Given this list of marker genes TTC39C, PSMB8, KCTD5, CDS2, ROCK1, ALS2, PLEKHO2, CASP1, NFATC1, ESCO1, FOXC1, RBKS, AHR, KIAA0319L, FHDC1, MCUB, THBD, ARSI, TUSC2, SOX18, PASK, SLC38A2, N4BP3, SYNGR2, EIF2AK2, ADI1, DLX3, CEBPA, RAB20, CD300LD, MRPS6, PALLD, TRIP12, TBC1D14, NFIL3, CTDSP2, PTGER2, ZNF207, ANGPTL2, MAF, TMEM131, IL10, ITGAE, TMEM267, ANKRD33B, HOXB4 (homeobox B4), KHDC1L, PROP1, NUDT22, RNF41, PTMS, TMEM268, ABCG1, IER5L, SUSD2, LIMA1, NPY2R, EDEM2, ST8SIA4, CYFIP1, RNF135, MMD, ABCB1, CD83, RBM38, RNF19B, HAUS3, AXL, SLFN12L, POGLUT2, NRP1, SCAF11, LAG3, SESN2, PAFAH1B2, FANCC, LDLRAD4, PMVK, SPSB1, TBXA2R (NCBI Gene Id 6915), GPM6B, GRHL2, NEK6, ENDOD1, GIMAP7, CASP4, HEY1, LRRC49, ARHGEF12 (NCBI Gene Id 55406), CPOX, RASA2, TIMP2, PEAR1, AOPEP, CBX6, PLEC, MTF1, SLC7A3, RPS6KC1, MRPL3, TGIF2, PTPN9, KIF13A, NAB2, FLNB, TGM2, SESN3, EHD2, PTPN11, TENT5C, LHCGR, ACAT2, HGD, MST1, REC8, GNA12, CD81 (NCBI Gene Id 975), MTM1, MYO1C, SLC22A23, ZNF436 (zinc finger protein 436), TBL1XR1, NPC1 (NCBI Gene Id 4864), TBX6, RWDD2B, KDM5C, SF3A1, CADM4, TNFRSF1B, ANO10, KIF5B (kinesin family member 5B), CFAP91, TMEM68, SLX9, METTL6, SRGN, RAB43, SLC35B2, RILPL2, GRN, SNX9, TLR4, SND1, CCNT1, PKM, NDUFA12, PANX1, UBE2Z, TMEM30B, CACNB1, TNFSF9, TRH, LUC7L3, LRBA, MMP10, TTF1, RSRP1, SLC16A3, CCDC117, CCNG2, TLNRD1, TRIP6, LCLAT1, MGMT, CDC5L (cell division cycle 5 like), CST7, TRAF1, GCC1, C7orf25, BGN, JMJD6, ANXA3, SAFB2, ITM2C, CXCR5, CASP3, DNAJB1, SSPOP, SDCBP2, SLPI, EDEM1, BCL3, TM9SF3 (NCBI Gene Id 56889), FGD1, TSPAN7, MPP2, SCAF4, PCDHA12 (protocadherin alpha 12), FOLR1, SLC7A10, HUNK, PPTC7 (NCBI Gene Id 160760), TTN, BTG3, CXCL16, RIPK2, SMG6, SRC, FEM1B, KCNJ2, here is a description of the gene set: studied in species Homo sapiens from publication Gattinoni L, Lugli E, Ji Y, Pos Z, Paulos CM, Quigley MF, Almeida JR, Gostick E, Yu Z, Carpenito C, Wang E, Douek DC, Price DA, June CH, Marincola FM, Roederer M, Restifo NP (PMID 21926977) Human Gene Set: GSE23321_CENTRAL_VS_EFFECTOR_MEMORY_CD8_TCELL_UP Genes up-regulated in CD8 T cells: central memory versus effector memory. An early-differentiated CD8+ memory T cell subset with stem cell-like properties (TSCM) can be identified within the naïve-like T cell population by the expression of CD95/Fas. Based on experiments including exon- and gene-level expression analysis, we provide evidence that this subset of antigen-specific cells represents an early precursor of conventional central (TCM) and effector (TEM) memory CD8+ T cells with enhanced self-renewal capacity and proliferative potential. We identified genes differentially expressed between major T cell subsets defined along with memory T cell commitment. Based on the analysis of these genes, CD95+ naïve T cells (TSCM) cluster closer to the CD8+ T memory compartment than to classical (CD95-) naïve T (TN) cells, and display an intermittent phenotype between classical TN and TCM cells in terms of all major T cell differentiation markers analyzed.